Given this list of marker genes SLC39A8, CTBS, GBE1, ZNF330, MPDZ, CDC14B, COQ9, BLCAP, TLR3, ZNF593, HMOX2, AK2, CRYBG1, MBNL2, KLF9, ACYP2, KAT2B, DGLUCY, LAP3, GADD45A, GCLM, GCHFR, TMED5, GCLC, SDHB, ABCB1, ALDH1A1, SPSB1, VKORC1, CTSB, SLC16A1, ABHD2, BTN3A3, TRIM2, HSD17B10, BTN3A2, GLRX, PRSS53, CYP7B1, CYP4F11, here is a description of the gene set: Hepatocellular carcinomas (HCCs) are a heterogeneous group of tumors that differ in risk factors and genetic alterations. We further investigated transcriptome-genotype-phenotype correlations in HCC. Global transcriptome analyses were performed on 57 HCCs and 3 hepatocellular adenomas and validated by quantitative RT-PCR using 63 additional HCCs. We determined loss of heterozygosity, gene mutations, promoter methylation of CDH1 and CDKN2A, and HBV DNA copy number for each tumor. Unsupervised transcriptome analysis identified 6 robust subgroups of HCC (G1-G6) associated with clinical and genetic characteristics. G1 tumors were associated with low copy number of HBV and overexpression of genes expressed in fetal liver and controlled by parental imprinting. G2 included HCCs infected with a high copy number of HBV and mutations in PIK3CA and TP53. In these first groups, we detected specific activation of the AKT pathway. G3 tumors were typified by mutation of TP53 and overexpression of genes controlling the cell cycle. G4 was a heterogeneous subgroup of tumors including TCF1-mutated hepatocellular adenomas and carcinomas. G5 and G6 were strongly related to beta-catenin mutations that lead to Wnt pathway activation; in particular, G6 tumors were characterized by satellite nodules, higher activation of the Wnt pathway, and E-cadherin underexpression. CONCLUSION: These results have furthered our understanding of the genetic diversity of human HCC and have provided specific identifiers for classifying tumors. In addition, our classification has potential therapeutic implications because 50% of the tumors were related to WNT or AKT pathway activation, which potentially could be targeted by specific inhibiting therapies. Human Gene Set: BOYAULT_LIVER_CANCER_SUBCLASS_G1_DN from publication Boyault S, Rickman DS, de Reyniès A, Balabaud C, Rebouissou S, Jeannot E, Hérault A, Saric J, Belghiti J, Franco D, Bioulac-Sage P, Laurent-Puig P, Zucman-Rossi J (PMID 17187432) Down-regulated genes in hepatocellular carcinoma (HCC) subclass G1, defined by unsupervised clustering species: Homo sapiens